Given this list of marker genes RUNX1, IKZF5, ITGA2B, HPS6, TBXA2R, ITGB3, EPHB2, here is a description of the gene set: Human Gene Set: HP_IMPAIRED_ARACHIDONIC_ACID_INDUCED_PLATELET_AGGREGATION Impaired arachidonic acid-induced platelet aggregation studied in species Homo sapiens Abnormal response to arachidonic acid as manifested by reduced or lacking aggregation of platelets upon addition of arachidonic acid.